Given this list of marker genes CBS, NOS1, APOE, RASD1, FPR1, ATP2B4, AGTR2, GUCY1A1, NOS3, NPY2R, NOS2, VEGFA, GUCY1B1, ENSG00000274276, DDAH1, THBS1, CD36, RILPL1, INS, KCNC2, NDNF, KDR, SPINK1, SCARB1, AGT, GUCY1A2, here is a description of the gene set: studied in species Homo sapiens Human Gene Set: GOBP_NITRIC_OXIDE_MEDIATED_SIGNAL_TRANSDUCTION An intracellular signaling cassette that starts with production of nitric oxide, detection by receptors/sensors for nitric oxide (such as soluble guanylyl cyclase/sGC) and ends with the activation of downstream effectors that further transmit the signal within the cell. Nitric oxide transmits its downstream effects through either cyclic GMP (cGMP)-dependent or independent mechanisms.